The following is a description of a gene set: Human Gene Set: REACTOME_TRANSCRIPTIONAL_ACTIVITY_OF_SMAD2_SMAD3_SMAD4_HETEROTRIMER Transcriptional activity of SMAD2/SMAD3:SMAD4 heterotrimer studied in species Homo sapiens, and this is the list of marker genes: ATP1B4, SP1, UBB, PPM1A, CDKN2B, SERPINE1, UBA52, SMAD2 (NCBI Gene Id 654050), CCNC, STAT1, E2F4, SNW1, SKIL, UBC, TFDP1, COL1A2, MYC, UBE2D1, RNF111, TRIM33, NCOR1, CDK9, SMURF2, EP300, SMAD7, USP9X, TGIF2, PARP1, WWTR1, NCOR2, SMAD3, TFDP2, MAPK1, CDK8, MAPK3, NEDD4L, CCNK, RBL1, SMAD4, SKI, CCNT2, MEN1, RPS27A, UBE2D3, FURIN, CCNT1, E2F5, YBX1, JUNB, TGIF1, HDAC1